The following is a description of a gene set: Fetal ascites Accumulation of fluid in the peritoneal cavity during the fetal period. Human Gene Set: HP_FETAL_ASCITES species: Homo sapiens, and this is the list of marker genes: HSD17B4, MDFIC, RHD, NPC2, NPC1 (NCBI Gene Id 4864), PTH1R, GNB2, EIF5A